Given this list of marker genes SFXN1, SLC6A7, SLC1A3, SLC1A6, SLC38A4, SLC38A6, SLC6A15, SLC7A5, SFXN3, SLC38A1, SLC36A3, SLC6A9, SERINC3, SLC7A7, SLC36A1, SLC1A4, SLC7A11, SLC7A9, SLC7A6, SLC38A3, SLC38A2, SLC43A2, ACE2, CTNS, SLC6A14, SLC7A13, SLC6A18, SLC6A17 (solute carrier family 6 member 17), LLGL2, SLC1A2, SLC25A12, SLC6A19, SLC3A1, RGS2, SLC1A1, SLC25A13, LEP, SLC32A1, SLC38A5, SLC7A8, NFE2L1 (NFE2 like bZIP transcription factor 1), SLC43A1, SFXN2, SLC6A5, RGS4, SLC3A2, SLC36A4, SLC6A6, SLC1A5, SLC36A2, SLC25A38, SLC1A7, CLTRN, SLC6A20, MFSD12, SERINC5, SLC38A7, SLC38A9, SLC7A10, here is a description of the gene set: species: Homo sapiens The directed movement of neutral amino acids, amino acids with no net charge, into, out of or within a cell, or between cells, by means of some agent such as a transporter or pore. Human Gene Set: GOBP_NEUTRAL_AMINO_ACID_TRANSPORT